Given this list of marker genes MGAT2, GET4, COG5, MAN1B1, ATP6AP2, COG4, COG8, ATP6V1E1, ATP6AP1, CAMLG, COG6, B4GALT1, COG1, TMEM199, COG7, SLC39A8, SLC37A4, here is a description of the gene set: Abnormal transferrin isoform profile consistent with a type II congenital disorder of glycosylation. Human Gene Set: HP_TYPE_II_TRANSFERRIN_ISOFORM_PROFILE Type II transferrin isoform profile studied in species Homo sapiens